The following is a description of a gene set: A single maxillary central incisor positioned in the midline with morphological symmetry of the crown and bordered by lateral incisors. species: Homo sapiens Human Gene Set: HP_SOLITARY_MEDIAN_MAXILLARY_CENTRAL_INCISOR Solitary median maxillary central incisor, and this is the list of marker genes: MID1, SHH, SIX3, GLI2, TGIF1, FOXH1, DLL1, STAG2, DISP1, FGFR1, SUFU, FGF8, BCOR, CDON (NCBI Gene Id 50937), STIL, SMAD2, PTCH1 (NCBI Gene Id 8015), GAS1, ZIC2, NODAL, EVC2, CRIPTO, CNOT1 (NCBI Gene Id 51579), ANKRD11, SMC1A, EVC, PLCH1